Given this list of marker genes PSMD4, PABPC4L, CIAO2B, PES1, CCDC69, LANCL3, MTRR, WDR17, PFDN6, PHB2, HDAC1, GOLT1B, LY9, DNAJA3, NF2, HSD17B7, MIR367, SNORD96A, PHYHD1, ARL5C, PRPF38A, PRMT1, TNFAIP8, SEPHS2, SDR16C5, TMEM186, NDUFS8, SMR3A, VPS16, GTF2H3, CDX1, CRLS1, LRRC63, NDUFA12, MRPL49, IPO5, TATDN2, ORM1, TBRG1, TMEM223, MIR491, LIPI, CNPY2, SLC25A45, DOHH, ETV2, PTPMT1, LCORL, PANK4, PHPT1, CAMK2N1, LRRC56, OAT, GRB2, ANKRD53, CD300LD, GKN2, MIF4GD, FAM118B, ATP6V0E1, SIRT4, CD82, L2HGDH, ASB13, TTC9, SLC39A7, TOMM40L, YARS1, HSPBAP1, RPL13, MIR532, RWDD1, GNB5, MCRS1 (NCBI Gene Id 10445), RNASE12, TMEM107, OSGIN2, AOC2, INHBC, NEPRO, RFXAP (regulatory factor X associated protein), TRADD, PHLDA1, MIR1-2, RNF41 (NCBI Gene Id 93069), CRIP1, CAMLG, GSTP1, RILP, CLDN16, RELN, TIMM17A, SIVA1, AGGF1, TXNDC5, MEPE, ANAPC16, PACSIN2, PYGB, IER5, PCYT2, PTPN18, PSMD9, PSMA5, METTL21A, OSGEP, KCTD20, DPPA4, MTARC2, RHOB, EIF3C, DERL1, AMFR, ANXA4, PSMG4 (proteasome assembly chaperone 4), CRADD, IL21, TACR2, EML3, SFMBT1, MMP20, MDH2, AHSA1, NPC2, HMGCS1, PFKL, CNGA1, SLC15A1, CDK5RAP3, BSCL2, MCCC2, PINK1, EIF2B4, SYTL2, GGTA1, GPR155, ACOT1, MMP9, PEF1, PPP5C, P2RY13, CHKA, ENTR1, TOMM5, PACRGL, CRYL1, DNAJC18, WDR24, ANKFN1, CD302, MRPL50, SFXN2, EXOSC2, TRAF7, SART3, SLC37A2, here is a description of the gene set: from publication Zhang W, Ferguson J, Ng SM, Hui K, Goh G, Lin A, Esplugues E, Flavell RA, Abraham C, Zhao H, Cho JH (PMID 22715389) In this study, we examined differential gene expression in naïve human CD4+ T cells, as well as in effector Th1, Th17-negative and Th17-enriched CD4- T cell subsets. We observed a marked enrichment for increased gene expression in effector CD4+ T cells compared to naive CD4+ among immune-mediated disease oci genes. Within effector T cells, expression of disease-associated genes was increased in Th17-enriched compared to Th17-negative cells. We used microarray to examine the gene expresssion profile and level of human naïve, Th1 and effector T cell subsets. Genes down-regulated in CD4 T cells: Th1 versus Th17 enriched. Human Gene Set: GSE32901_TH1_VS_TH17_ENRICHED_CD4_TCELL_DN species: Homo sapiens